Given this list of marker genes BBX (BBX high mobility group box domain containing), KBTBD4, MRPL18, NDUFB11, ZDHHC9 (NCBI Gene Id 93950), HDAC4, GSK3B-DT, CCDC61, ZNF691, MZT1, NCDN, SLC43A2, ATPAF2, PLPBP, QRSL1, MYL11, METTL23, LRPPRC, ATG4C, ATP5F1B, SUGP1, ZNF343, CBX3, UFD1-AS1, CHASERR, IL10RA, ZNF267, ZSWIM4, YBX1, PRPF31, CENPK, ZNF689, ENSG00000207751, TASOR2, CPSF2, DDA1, SRP19, NSDHL, STARD7, ZNF774, PCGF3-AS1, PDXDC1, NDUFB1, ZMYM2, SMARCA2, MIR3143, ZNF169, SPAG7, SETD3, PSMA5, ARL6IP6, ISCA2, CCNL2, CDCA8, ATP6AP1, MED30, CDK11B, CEBPG, NR2C2, RTP4, PTRH1, MTHFD2, SPRING1 (NCBI Gene Id 79794), AP2S1, NCOA2, GPR108, SZT2, ANKRD16, CDK11A, RERE, HRAS, PRMT1, SMPD4P1, NARS1, IK, PLA2G15, STAT3, SFPQ, PAXIP1-AS2, PER1, MYH10, ZNF257, CLPB, ERI3, SLC25A25, COPZ1 (NCBI Gene Id 51644), ZCCHC17, RNF5, USP1, TOMM40, SLC25A53, ATF7IP2, ZNF597, ENSG00000267698, ING1, GRK4, UQCRC2, FAM156A (family with sequence similarity 156 member A), TCERG1 (transcription elongation regulator 1), ZNF292, KIF1B, P2RX6P, APTR, H2AX, BRCA1, DERL3, CENPA, ENSG00000272008 (NCBI Gene Id 124901355), PROSER3, ARID4B, ZNF675, ARPC3, CREBRF, OARD1, LIN37, ZNF227, MVK, ECT2, TLE6 (TLE family member 6, subcortical maternal complex member), TBC1D10B, C17orf58, RBM27, NDUFAF2, CENPE, RPL32, LRRC41, H2BC15, NDUFB3, ACYP1, CCNF, RACGAP1, SIN3A (SIN3 transcription regulator family member A), CYB5B, TARS2, DHCR24, CYB5RL, PMEL, ZNF688, DNAJB5-DT, INPP5B, ZNF93, ANKHD1-EIF4EBP3, MCPH1-AS1, EFNB2, EFCAB11, ZNF189, EP400P1, LINC01756, RTN4, HNRNPA1, CBX8, GLTC1, CDCA7, CBY1, TRIM59-IFT80, TMEM260 (transmembrane protein 260), BOD1 (NCBI Gene Id 91272), MIA2-AS1, GBF1, RAB3D, ZNF654, ERCC5, PARP16, NSFL1C, EPB41L4A-AS1, CREB3L3, SBNO1-AS1, INCENP, HNRNPAB, METTL17, ZFHX3-AS1, TTC41P, RABL3, DHCR24-DT, RNVU1-15 (NCBI Gene Id 105373467), PER2, DDX23, TTC9C, MOSPD3, ZNF253, CKS2, MIR301B, ZDHHC5, ZNF317, ASPM, PSMC5, EFCAB6 (NCBI Gene Id 64800), RBM48, SNRNP25, KPNA4, UGP2, MICE, HIKESHI, SRGAP2, TMEM217, IFRD2, TUBA5P, CENPN, WDTC1, H2BC7, BANP, MPV17L2, SNORD59A, HIRA, CCDC163, RBM3, SKA2, SEPTIN6, MBOAT2, ZNF724, ZNF77, SNAI3-AS1, RITA1, BAHD1, RMND5A, TNPO2, LRRC74B (leucine rich repeat containing 74B), PSMD4, FAHD1, SPC25, CEP192, UBA1, UBC, ARF3, TARS1-DT, HMGCS1, MDM1, SFXN5, SNHG10, LENG1, CEP131, STXBP5-AS1, RAB11B, PLAC1, TNRC6B, ZNF493, CARS2, NBR1, CEP95, CIC, ARMH4, HJURP, MPND, TYK2, WDTC1-DT, RPS11, ATG16L2, TMEM205, H2AZ2, SRGAP2C, CCNB1, TANGO2, APC2, MBD6, RNASEK, ZNF300, ANAPC5, SELENOO, CALCOCO1, TMEM60, KIF18B-DT, STARD4, MATCAP1, C1QTNF6, FAM222B, EEFSEC, PAN2, CIT, PPP5D1P, KRBOX5, LRRC45, SLC39A3, LIM2-AS1, ACTL6A, PHPT1, VIPAS39, CYP2R1, BORA, ZZZ3, CNOT3, LIPE-AS1, LARS1, DNM2, FAAP24, SARNP, BAZ1B, AURKA, CAMTA1, JPT1, LINC00642, TMEM94, SCAI, VBP1, GTF2H4, H4C2, H4C4, ELMO2, CGGBP1, LMBR1L, LNX2, FHIT, RBM4, ZBTB3, KHSRP, DOLPP1, C3orf18, IL23A, ARVCF, KMT5C, DCAF4, ZNF133, STAP2, MEIS1, RFWD3, FKBP8, MAGI3, CD101-AS1, RBM42, GLRX5, TRIM59, NGDN, UBE2I, TSPAN31, TAFA2, ATP5PD, TMEM256-PLSCR3, ZSWIM3 (NCBI Gene Id 140831), AAMP, RIOK2 (NCBI Gene Id 55781), TUBB4B, FADS2, DNAJB5, KCNQ1OT1, FAM53C, PDE6D, H2AC7, ZNF8-ERVK3-1, TOM1L2 (target of myb1 like 2 membrane trafficking protein), UIMC1, FRG1-DT, ATG9A, MRPL27, BRIP1 (NCBI Gene Id 83991), TTBK2, GIPC1, EBP, FOS, SETD5, STARD3NL, DHRS2 (NCBI Gene Id 10202), CDC23, H2AC11, C1orf216, H2AZ2-DT, PANK2, AKAP8, CDR2-DT, CENPX, RPS15AP37, ARMH1, LYPLA2, WDR45, CLSTN3, TPRA1, SELENOW, DYNC1I2, REEP6, STYXL1, CCDC66, CHD6, LINC01511, WARS1, CCDC77, PRCP, ZBTB5, H4C12, RHCE, RAB40B, PAXIP1-DT, HDAC4-AS1, DCTN4, GTF2E1, GLCCI1, FDFT1, TK1, DICER1-AS1, DEF8 (NCBI Gene Id 54849), RNF26, PIF1 (PIF1 5'-to-3' DNA helicase), HSPA8, KLF6, ZNF436, LMNTD2, TPD52L2, CYB5A, CFAP20, SMIM12, TICRR, CCNJ (NCBI Gene Id 54619), RCL1, UBQLN4, EEF1E1, BAGE2, RHBDD3, CEP192-DT, MIR4479, FTSJ3, EDEM3, KDM4A-AS1, ABCA11P, UBE2Q1, TEPSIN, H4C3, CPEB4, FBXO8, ZNF574, HSPB6, SSX6P, ZNF195, ZNF555, RNF34, SMUG1, C19orf81, H2BC26 (H2B clustered histone 26), RIMBP2, C9orf85, LINC02210-CRHR1, LRP4-AS1, SAMTOR, TOGARAM1, MSH2, HNRNPUL2 (NCBI Gene Id 221092), ONECUT2, CTPS1, ARL13B, TIMM8B, ZNF436-AS1 (ZNF436 antisense RNA 1), PNPO, CTTNBP2NL, FBH1, EVI5L, SDHD, MRPS12, UFD1, CMC2, R3HDM1, ILF3-DT, ZBTB20, LMCD1-AS1, HLTF, ANP32E, RFX1, HNRNPR, KANSL2, ENSG00000251574, ENSG00000275765, NDUFS3, TCP11L2, MMAB, PMVK, SYNGAP1-AS1, TRIM68, CFAP221, COASY, SLC25A11, RPL32P3, AREL1 (NCBI Gene Id 9870), TTLL5, CDCA3, FCF1P8, CA11, ATG3, COQ8A, POLR1G, POLR1D, PABPN1, PGAP2, ZNF626, DNAJC28, THAP8, INVS, TMEM45A, MIR22HG, WRAP53, RNVU1-19, NAP1L4, STK35, GATAD2A, TRIM11, COPS5, PDIA6, TPRN, SERTAD2, TDRKH (NCBI Gene Id 11022), DOHH, PRDM2, GP6-AS1, COQ7-DT, STK11IP, WDR25, GSK3B, KCTD2, TMEM218, CACNA1G (calcium voltage-gated channel subunit alpha1 G), PPM1B, KAT6B, LLPH-DT, ST3GAL2, TMEM248, TMEM38A, ZBTB9, SLC25A28 (solute carrier family 25 member 28), ST3GAL3, DUSP10, XNDC1N, DNAAF6, ZDHHC13, HMG20A, RNF167, XRCC3, ANKRD28, PDCL, IL6ST, ACTN1, TARDBP, PAXIP1, KCTD9, C21orf58 (chromosome 21 open reading frame 58), H2AC4, ZNF726, CEP89, RPL38, LINC02210, ISOC2, SP1, AP1G1 (adaptor related protein complex 1 subunit gamma 1), NAIF1, DRC3, HACL1, WDCP (NCBI Gene Id 80304), CANX, SARS2, NCK2, SH3D21, FDPS, ABHD17B, TMEM208, MRPL50, DPH2, AKIRIN2, DYNLL1, PNN, GSPT1, RAD54L, GPR137C, MRPL37, AGPAT1, ISLR2, PLCL1, MED29, COL23A1, ID2, ARHGAP19-SLIT1, CDC25C, MED24, DAPK3, PWWP2A, LAMTOR2, FGF7, SLC46A3, H2BC12, ETF1, PPP2R5E, ABHD8 (abhydrolase domain containing 8), OR1AB1P, H2BC11, SLC49A4, AHSA1, MED19, ZNF837, ZNF678, CNPY3, MCM5, ENTPD1-AS1, FBXL9P, SRP9, NUP98, AP3M2, CUL2, CHD9, PQBP1, BCAS3, CDC45, LYRM1, FAR1, FRYL, PRR14, RHPN1-AS1, XAB2, SORT1, G3BP1, CHCHD2, DENR, GATAD2B, NRAV, HSF2, LINC01287, RNFT1-DT (RNFT1 divergent transcript, NCBI Gene Id 101927755), MXD4, CCZ1, RRBP1, CENPQ (centromere protein Q), SERTAD1, CCNK, SNX32, METTL13, ERP44, LANCL2, ARHGAP19, CDR2, SLC11A2, RNVU1-26, PTDSS1, MCM3, KIF9, H4C8, OSTC, PNKD, SNRPB2, ZNF300P1, GOT1, ZNF714, XRCC4, RAB8A, NSUN5, CDCA7L, ANKRD39, KPNB1-DT, ACTG1P25, SPNS1, IREB2, ERCC8, PSIP1, KIAA0319L, DNAAF3, RASSF7, CETN4P, ZNF738 (NCBI Gene Id 148203), TRAF2, SSBL4P, CBLN1, HNRNPK (NCBI Gene Id 3190), ADD1, ZBED5-AS1, ATP8B3, CCZ1P1, PDXDC2P-NPIPB14P, SHKBP1, DGAT2-DT (NCBI Gene Id 283214), STAG3L3, NOSIP, HINFP, TMTC4, WDR6, CDK2AP2, WDR36, COPE, PPP1R13L, ATXN2L, CCT7, TTC23, WHAMM, TMPOP2, LRRC28, THUMPD3-AS1, POLR2I, TMEM160, FRAT1, MBTD1, UBE3B, WBP1L, CCNB2, AGPAT5, NOL6 (NCBI Gene Id 65083), LCMT1-AS1, ZNF138, SNRNP40, LMCD1, DICER1, EIF5, FUT8, SSX1, CFAP96 (NCBI Gene Id 441054), NUMB, RNFT1, MTRR, PGK1, NRDC, MDH2, KLHDC9, HYCC2, ANKZF1, ABCB8, BAIAP3 (NCBI Gene Id 8938), LINC00240, SLC35F2, RAB5C, IBTK, CABIN1, H2AC15, KATNB1, NDUFA2, FASTKD3, LINC01257, ZNF43 (NCBI Gene Id 7594), ABHD2, KLHL25 (kelch like family member 25), USF3, ZNF143, STK11, STK40 (serine/threonine kinase 40), PRR11, PANK2-AS1, DNAJC11, YJU2B (YJU2 splicing factor homolog B), ZFYVE21, PEX1, RAB3A (NCBI Gene Id 96387), MSANTD4, FBXW11, EEF1D, BROX, TP53BP1, ZNF66, PYCR2, DAP3, CREB3L4, FAM227A, FEN1, ZNF8-DT, LINC02960, LINC01572, HAGH, ATF7, CKAP2, GTPBP3, SNRPE, NEK3, ANKRD23, PMF1, TCP1, TEDC1, BBS12, FAM83D, MRPS18B (mitochondrial ribosomal protein S18B), EZH2, ARL4A, SLC17A7 (NCBI Gene Id 57030), TXNIP, RSBN1L, KCNAB2, VEZT, PIPOX, SNX12, SAP30L, MAU2, TDRKH-AS1, ZWINT, SMYD3, ZBTB22, UFSP2, E2F3, NUCKS1, DGAT2, SKIC2, ZDHHC16, PTCD3, PAIP2B, WDR89, PRPF40A, RMI1, ATP5IF1, PCNT, EEF1E1-BLOC1S5 (EEF1E1-BLOC1S5 readthrough (NMD candidate)), MSMO1, MTMR4, HMMR, CAMTA1-DT, PDXP-DT, NFATC2IP, ERI2, TSPYL6, SPC24, DLGAP5, RNF6, ZNF8, LMO4, EME1, AP2A1, ERCC6L2, ANKHD1, MPHOSPH8, POGLUT2, KIF18B, ATP6AP1-DT, IL6ST-DT, MLEC, NFYA, TTLL7 (tubulin tyrosine ligase like 7), PLA2G4E-AS1, ERCC6L2-AS1, YPEL2, SLC25A42, PC, ROGDI, ATP5MC1, CNOT1, CDK16, IFT27, MTMR9, DMXL1-DT, STT3A, ZNF680, POLG, GRIPAP1, IARS1, RPS19, ARB2A, GTF2A1, CDIPTOSP, MFSD12, FKBP14, RPS7, SCYL3, NDUFS8, RNFT2, ADPRHL1, LMAN2, MTCH1, SP3, PASK, POLR3K, RNU2-17P, ZNF526, NARF, ZMYM5, EIF2AK3-DT, NELFE, LTN1, ARPC4-TTLL3, EMC9, RGS9BP, ZNF721, CNNM3, CCHCR1, RPS27A, PARP3, PFDN4, TCAM1P, ACOT8, HSPA5-DT (NCBI Gene Id 107987127), TNPO3, YPEL1, ANAPC15, ZNF785, NEK10, GACAT1, CCDC144NL-AS1, MDC1, CEP41, UQCRH, ZNF718, PPP1R3F, FRG1, RALB, CENPF, EDF1, CDKN3 (cyclin dependent kinase inhibitor 3), CALM3, CCDC144NL, RCN2, BCCIP, LAMP1, ANP32A, SUN1, CASP8AP2 (NCBI Gene Id 9994), SSR3, ARHGEF10, ZNF691-DT, RPL19, ZNF226, HNRNPC, TRIOBP, ZNF107, ATP8A1 (NCBI Gene Id 10396), OSBPL9, GOLT1B, CHMP4B, ZNF695, GBA1LP, ZNF384, PRSS3, ENSG00000224905, GGCT, ADGRD1, GDF11, MGRN1, FOXK2, ENSG00000261335, ZSCAN20, KLHL6, NUDT16-DT, HNRNPL, CEP295, STPG1, RNASEK-C17orf49, FBXO24, RPS3A, ADGRD1-AS1, FAM72A, SSR4, PHRF1, NLK, H4C5, H4C11, NARF-AS2, SPTLC2, PHTF2, F11R, WDR62, MIA, COPS3, CETN2, EML2, PEAK1, LINC01971, NUDT2, ANKRD11, NUDT21, YIF1A, MRPL20-AS1, PDP2, LSM4, CAT (catalase), SMTN, NEMP1, BUB3, ZC2HC1C, PLEKHA8, TBCB, MRPL24, ASAH1, ARID4A, MIA2, ZNF117, MED8, RBM10, ZBED5, HES1, HAPSTR1, FAM117A, H3-3B (H3.3 histone B), CKAP2L, DDX50, FER, LINC00431, TM9SF4, ZNF225-AS1, CCZ1B, HSPA5 (NCBI Gene Id 3309), UVRAG, LRCH4, FUS (FUS RNA binding protein), YWHAQ (NCBI Gene Id 10971), KCTD10, GOLPH3L, CENPM, LINC02926, SCAMP2, PGD, ARRDC4, NAA60, TMEM256, ETV5, FBXO33, AHCYL2, ZBTB18, GNB2, ZNF273, ZNF736, C7orf50, RTN4IP1, DDX49, MTR, UFC1, TMEM161A, RFX2, NRL, FAM32A, FCF1, CALN1, HAUS8, NXT2, CLUHP3, TBC1D17, NF2, OIP5-AS1, ANKRD27, PCLAF, DHCR7, ANKRD54, MIR5188, SP2, IFT52, MAP3K3, STX4, KDM4B, ZNF417, MAEA, TAF15, ELOC, AK2, RAB4B, RAB39A, ASAH1-AS1, CDK1, IQCH, EXOC4, SNORA13, CDCA2, MMACHC, COPS7B, DCUN1D3, DDX54 (NCBI Gene Id 79039), KPNB1, DHX38, KANK3, CBX5, PDK2, SPG7, DCP2, MAF1, LEMD3, ESCO2, YJU2, AEN, YY1AP1, ERV3-1, PPP6R3, H2AC12, TMEM258, TMEM70, GATB, STRIP1 (striatin interacting protein 1), FAM168A, PHB1, TRAPPC6A, TXNL4B, ADAD2, FLCN (folliculin), ACO2, GOLGB1, RNF121, NR2F2-AS1, ACTN1-DT, TMEM167A, DEDD2, TMEM97, PSMA3-AS1, AFMID, ZNF225, JPT2, CRTC2, LCMT1, XPO1 (exportin 1), HGS, ILF3, OXLD1, PAF1, RFC1, TOMM40L, SNRPF-DT, H2AC25, EED (NCBI Gene Id 8726), RNF181, KAT7, LAMTOR4, CDKL3, SHARPIN, ARMC1, C10orf143, ZNF775, GLO1, FLAD1, CDON, INTS4, CLK3, KLF10 (KLF transcription factor 10), ZNF687, ALDH4A1, CSTF1, RC3H2, ZNF175, BZW1, OTUB2, HNRNPUL1, MMUT, NUDT13, TOP2B, PTMA, GNA12, MORN4, LCA5, TMX2, CKS1B (NCBI Gene Id 88475), PDE12, HMGB1, TPST1, NUDCD2, PIN1-DT, IP6K1, CSE1L-DT, HLA-F-AS1, ZSWIM1, TPX2, ENSG00000273727, BLOC1S3, PKP4 (plakophilin 4), DDOST (dolichyl-diphosphooligosaccharide--protein glycosyltransferase non-catalytic subunit), HSPBAP1, RALGPS1, UBR2, TMEM115, GLA, SLC26A2 (NCBI Gene Id 1836), EXOSC1, NUDT16 (NCBI Gene Id 131870), FNBP4, NFKBIB, FGD6 (FYVE, RhoGEF and PH domain containing 6), MTMR12, HBP1, DDX19B, GTPBP6, DAZAP2, ZNF100, YIPF4, NR6A1, SAP130, HMGN3, MTOR, USP15, TTC16, MIR3181, MRPS30, TSPAN15, RNF13, KLHDC10, MSTO1, MRPS30-DT, PDXDC2P, CHAF1A, OLMALINC, AKAP8L, TRABD-AS1 (NCBI Gene Id 124905148), HSCB, USP5 (ubiquitin specific peptidase 5), PIGN, SLC35E2A, PPP1R10, SLC25A28-DT, FEM1A, ZNF564, ELAC2, ZNF701, NDUFAF8, RRP9, CCNB1IP1, BLZF1 (NCBI Gene Id 8548), GTPBP1, CDK12, PTP4A2, PKNOX1, ORMDL2, COX6B1, CYTH2, PPWD1, ATG101, PPIA, TUBGCP5, CCDC174, TBC1D22B, PHF5A, HNRNPUL2-BSCL2, COTL1, SLC39A1, HDAC8, HERC3, PRKCI, MIA-RAB4B, CEP44, WDR81, VCP, KLF5, AGBL5, TSACC, RBL2, CSPP1, ENSA, RP2, CDIPT, SMIM7, ZMYND8, IMMP1L, COQ7 (NCBI Gene Id 51672), SLC2A8, UBALD2, HDDC2, MYO9B, ZNF431, MIR29B2CHG, AARS1, JUP, UTP18, ENSG00000239137, ZNF101, ZNF341-AS1 (NCBI Gene Id 101929746), CEP164, BPGM, MEIS2 (Meis homeobox 2), TFPT, LTBP4, PDXP, ALKBH6, HDGFL2, WBP1, ID2-AS1, PMF1-BGLAP, SNX11, CHEK2, TOP2A, RELCH, MIR4999, RTRAF, PACSIN2, SP2-AS1, ZNF622, TPI1P2, AAGAB, FGD5-AS1, TTF2 (NCBI Gene Id 8458), CCDC137, ELP4, FICD, ENSG00000275740, SSX3 (SSX family member 3), CCDC148, GOLGA3, FBXO5, RPL18A, DDIAS, PRKCE, PSMB3, SMARCE1P5, RPL6, PPP2R5A, SLC35A5, ACAP2, ZNF519, ACBD4, HYCC1, TMEM45B, ANKHD1-DT, VARS2, AIDA, PRRG2, DDIT3, TIMM17B, SMC3 (NCBI Gene Id 9126), KCNH5, TCTN3, NOP14, C5orf22, SRI, MAT2A, VPS4B, MSL3 (NCBI Gene Id 25867), RHPN1 (rhophilin Rho GTPase binding protein 1), TRIP10, RAB28, ARL16, TCF19, MANF, DHFR2, SLC25A19, NUCB2, UNG, GOT1-DT, TESK2, DNAI3, MTERF3, AFF1, MAOA (monoamine oxidase A), CCT3, ILF2, SHC1, UROS, POLR1A, DDX5 (NCBI Gene Id 1655), SAPCD2, C22orf39, PPP1R7, ANKFY1, ACAT2, NPHP4, CHCHD6, NME7, NUP62CL, HNRNPA2B1, UBE2B, HNRNPH2, OGFOD1, SNRPF, BIVM, PCSK4, PIN1, JMJD6, COX7C, FCHO1 (FCH and mu domain containing endocytic adaptor 1), TAF2 (TATA-box binding protein associated factor 2), ADAMTSL5, ERCC2, MPRIP, FMN1, RECQL, TADA3, STX5-DT, CNEP1R1, BCL6, LAPTM4A-DT, TRAFD1, TMPO, FBXL19, EHD4 (EH domain containing 4, NCBI Gene Id 30844), RUVBL1, CKAP5, MPZL1, CKAP2-DT, LLPH, ATP6AP2, RND1, LINC00856, FAM72B, GID4, BTD, ZNF556, KLHL28, H3C12, TXNDC16, SS18, NABP2, DROSHA, DDX39A, NIPAL3, ALKBH7, POLG-DT, NSUN3, TULP3, FAM204A, RPS26, RAP2B, PSAT1, WFS1, INTS3, PRADC1 (NCBI Gene Id 84279), SAP30L-AS1, STIP1, RAB11B-AS1, MTFR2, ZFTRAF1, XIST, CLHC1, CEP68, P4HB, WDR83, EWSR1, PET100, NPC2, DISP3, BUB1, ZNF611, MARCHF2, TIGD5, HINT2, ARPC4, PTBP1, GGPS1, TARS1, TNRC6B-DT, DCAF11, MYL12A, KANSL1, NLGN2, MPP2, EIF2AK3, DCUN1D4, DHCR7-DT, RAB4B-EGLN2, AKR1E2, SYF2, KCTD7, PDIA4, FAR1-IT1, CCDC159, COMMD6, SNX16, PXMP4, TMEM53, BCL2L1, DCAF7, BMAL1, ENSG00000224865 (novel transcript), TDP1, ORC2, GTF2A1-AS1, EFCAB6-DT, WDR83OS, BABAM1, PRKACA, CD70, ZKSCAN5, ATF7-NPFF, ZNF552, SPRYD3, DCAF15, ZRANB3, ATP8A1-DT, FYN, RAB5B, PHF12, SUCO, ENSG00000224478, ING4, ZNF143-AS1, DMXL1, KPNA2, HSP90B1, KLHL18, ABCA7, CALR, RBM39, HYAL2, CHRNB1, MACO1, MVD, ZNF92, PGP, SIRT2, AIRIM, STAG3L1, CFAP43, TMBIM6, MIR638, ZNF687-AS1, CYLD, SPSB3, NUBP2, here is a description of the gene set: studied in species Homo sapiens from publication Yevshin I, Sharipov R, Kolmykov S, Kondrakhin Y, Kolpakov F (PMID 30445619) Genes containing one or more binding sites for (ASH1L) in their promoter regions (TSS -1000,+100 bp) as identified by GTRD version 20.06 ChIP-seq harmonization. Human Gene Set: ASH1L_TARGET_GENES